The following is a description of a gene set: studied in species Mus musculus The lipid bilayer surrounding any of the compartments of the endoplasmic reticulum (ER)-Golgi intermediate compartment system. Mouse Gene Set: GOCC_ENDOPLASMIC_RETICULUM_GOLGI_INTERMEDIATE_COMPARTMENT_MEMBRANE, and this is the list of marker genes: Sec22b, Tmed2, Atp6ap1, Ergic1, Ergic3, Zdhhc20, Tmem199, Nat8f2, Nat8, Tmed3, Tmed9, Sting1, Golga2, Stx17, Nat8f4, Robo1, Nat8f6, Lman1l, Lamp5, Vma21, Rab2a, Dcstamp, Cln8, Nat8f1 (NCBI Gene Id 66116), Kdelr1, Sppl3, Aspscr1, Piezo1 (piezo-type mechanosensitive ion channel component 1), Tmed1, Nat8b-ps, Stx5a, Bcap31, Mppe1, Nat8f5, Yif1a, Ergic2, Vps13b, Lman1, Tm6sf2, Plpp3, Mgat4d, Surf4, Slc35c2, Nat8f7, Whamm, Vmp1, Tmed10, Copz2, Azin2, Tmed5, Prrg4, Nat8f3